The following is a description of a gene set: species: Homo sapiens Human Gene Set: HP_ABNORMAL_CSF_CARBOXYLIC_ACID_CONCENTRATION Any deviation from the normal concentration of a carboxylic acid in the cerebrospinal fluid. Abnormal CSF carboxylic acid concentration, and this is the list of marker genes: PSAT1, PIGA, D2HGDH, IBA57, LONP1, GCSH, PEX12, AMT, SLC13A3, GLYCTK, PDHA1, ASL, NDUFA4, NADK2, AASS, ALDH5A1, BCKDK, ADK, DLD, GLUL, SLC25A1, DLAT, GCH1, NFU1, BOLA3 (bolA family member 3), PET117, PDHX, MECP2, GLRX5